Given this list of marker genes Ptgdr (prostaglandin D receptor), Cysltr1, Ltb4r1 (NCBI Gene Id 16995), Ptger2, Tbxa2r, Cysltr2, Ptger4, Ptger1, Ptgir, Ptgdr2, Gpr17, here is a description of the gene set: studied in species Mus musculus electronically inferred by orthology from the curated human pathway part of: Class A/1 (Rhodopsin-like receptors) This event has been computationally inferred from an event that has been demonstrated in another species.<p>The inference is based on the homology mapping from PANTHER. Briefly, reactions for which all involved PhysicalEntities (in input, output and catalyst) have a mapped orthologue/paralogue (for complexes at least 75% of components must have a mapping) are inferred to the other species. Reactome Pathway: Eicosanoid ligand-binding receptors